Given this list of marker genes ABCD1, MIR132, AVP, IL1B, PIBF1, PTGS2, MIR766 (NCBI Gene Id 768218), ABCD2, SIRT1, PLA2G3, PLAA, FABP5, MIR204, AVPR1A, CD74, here is a description of the gene set: species: Homo sapiens Any process that modulates the frequency, rate or extent of unsaturated fatty acid biosynthetic process. Human Gene Set: GOBP_REGULATION_OF_UNSATURATED_FATTY_ACID_BIOSYNTHETIC_PROCESS